Given this list of marker genes SMARCD2, ACTB, SMARCC2, BCL7C, BRD7 (NCBI Gene Id 29117), SMARCE1, SMARCA2, SMARCB1, SMARCD1, SMARCC1, BCL7A, ACTL6A, SMARCD3 (SWI/SNF related, matrix associated, actin dependent regulator of chromatin, subfamily d, member 3), SMARCA4, PHF10, ARID2, PBRM1, BCL7B, here is a description of the gene set: Formation of the polybromo-BAF (pBAF) complex species: Homo sapiens Human Gene Set: REACTOME_FORMATION_OF_THE_POLYBROMO_BAF_PBAF_COMPLEX